The following is a description of a gene set: Human Gene Set: KEGG_MEDICUS_VARIANT_LOSS_OF_NKX3_1_TO_PI3K_SIGNALING_PATHWAY Loss of NKX3-1 to PI3K signaling pathway. Pathway ID: N00082. Pathway type: Variant. Pathway class: nt06272 Prostate cancer. species: Homo sapiens Pathway Definition from KEGG: NKX3-1* // AKT -| BAD, and this is the list of marker genes: AKT2, AKT1, AKT3, NKX3-1, BAD